Given this list of marker genes REPIN1, ZNF276, CTCF, ZFX, CTCFL, here is a description of the gene set: Binding to a chromatin insulator sequence, a DNA sequence that prevents enhancer-mediated activation or repression of transcription. species: Homo sapiens Human Gene Set: GOMF_CHROMATIN_INSULATOR_SEQUENCE_BINDING